Given this list of marker genes HESX1, ETV2, ACTBL2, PPFIA2, CREB3L3, here is a description of the gene set: COMMD1 (previously known as MURR1) belongs to a novel family of proteins termed the copper metabolism gene MURR1 domain (COMMD) family. The 10 COMMD family members are well conserved between vertebrates, but the functions of most of the COMMD proteins are unknown. We recently established that COMMD1 is associated with the hepatic copper overload disorder copper toxicosis in Bedlington terriers. Recent in vitro studies indicate that COMMD1 has multiple functions, including sodium transport and NF-kappaB signaling. To elucidate the function of Commd1 in vivo, we generated homozygous Commd1 null (Commd1(-/-)) mice. Commd1(-/-) embryos died in utero between 9.5 and 10.5 days postcoitum (dpc), their development was generally retarded, and placenta vascularization was absent. Microarray analysis identified transcriptional upregulation of hypoxia-inducible factor 1 (HIF-1) target genes in 9.5-dpc Commd1(-/-) embryos compared to normal embryos, a feature that was associated with increased Hif-1alpha stability. Consistent with these observations, COMMD1 physically associates with HIF-1alpha and inhibits HIF-1alpha stability and HIF-1 transactivation in vitro. Thus, this study identifies COMMD1 as a novel regulator of HIF-1 activity and shows that Commd1 deficiency in mice leads to embryonic lethality associated with dysregulated placenta vascularization. Genes up-regulated in normal 9.5 days post coitus (dpc) embryos compared to normal 8.5 dpc and 9.5 dpc embryos. Human Gene Set: VANDESLUIS_NORMAL_EMBRYOS_UP from publication van de Sluis B, Muller P, Duran K, Chen A, Groot AJ, Klomp LW, Liu PP, Wijmenga C (PMID 17371845) species: Mus musculus